Given this list of marker genes LGALS1, FAS, MKI67, SERPINB2, MPHOSPH6, FGF4, CCND2, TNFSF14, BIRC3, LALBA, E2F1, GSPT1, PCNA, BIK, LGALS3, PLK1, E2F3, MBL2 (NCBI Gene Id 4153), NUPR1, WEE1, CCNB1, CDK8 (cyclin dependent kinase 8), BNIP3, NEDD9, NFKB1, CLEC2B, CDK6 (NCBI Gene Id 1021), CDC20, RAN, BCAR3 (NCBI Gene Id 8412), CDK4, BCL2A1 (BCL2 related protein A1), DUSP6, G0S2, KLRK1, IFITM1, CD2, BIRC2, FASLG, MX1, EREG, MYBL2, IL1B, SON, BNIP3L, CDC45, IER3, NRAS, STK17B (NCBI Gene Id 9262), TNFSF10, FCER2, CD69 (NCBI Gene Id 969), UBE2V2, IL1A, BCL2L1, BIRC5, MPO, CFLAR, BNIP2, DNAJC3, here is a description of the gene set: studied in species Homo sapiens Genes in the cancer module 254. Human Gene Set: MODULE_254